Given this list of marker genes CDKN2A, BCL10, DKC1, PTPN22, COL17A1, TRANK1, BRAF, KRT6B, KRT17, CLCN6, HNF1A, NTRK1, PHOX2B, UCP2, BIRC3, EPAS1, THPO, KIF1A, GNA14, ATP1A2, RET, SLC12A3, CFTR, SDHD, WNT10A, BOLA3, YY1, FLRT1, CACNA1S, ZNF365, USB1, NOP10, SLURP1 (secreted LY6/PLAUR domain containing 1), HPGD, GABRA3 (gamma-aminobutyric acid type A receptor subunit alpha3), WNK1, NPM1, TERC, TINF2, ADAMTS15, SDHB, IKBKG, HEXB, SLC25A11 (solute carrier family 25 member 11), MPL, CTNNB1, TERT, PARN, RSPO1, GLA, HINT1 (NCBI Gene Id 3094), CCND1, KCNJ11, TNFSF4, ATP1A3, KCNA1, IGF2, MALT1, MOG, SCN11A, TAT, IGHMBP2 (immunoglobulin mu DNA binding protein 2), HLA-DRB1, DST, KIF1B, CACNA1A, NECTIN1, HMBS, CLCF1, PLAA, JUP, H19, SUCLG1, MAX, TP53, LPAR6, FBXO11, ZNRF3, SLC39A14, SHQ1, DNMT3A (DNA methyltransferase 3 alpha), HCRT, HLA-DQB1, FGFR2, P4HA2, KRT16, ALDOB, KRT5, FOXP1, LIFR, MBTPS2, FH, SERPINB7, CRLF1, KRT1, CTC1, SPR, CNBP, KCNJ18, KRT14, KRT9, MAP2K2, SDHAF2, VHL, FUCA1, KLC2, CDH3, HLA-B, SPRED2, CTSH, CUL4B, CLCNKB, AIP, TRPV3, MEN1, TYMS, HNRNPK, DLST, RETREG1, SLCO2A1, SDHA, COL6A1, TMEM127, NLRP3, GRB10, LAMB3, SLC18A2, CTSB, SLC1A3, CDH23, ABCC8, CDSN, SDHC, HNF4A, MDH2, NF1, MAP2K1, DDC, PRNP, DSG1, NHP2, NGLY1, PERP, ELP1, SUCLA2, AQP5, JAK2, KRT6A, SCN9A, P2RY11, GPR101, HRAS (HRas proto-oncogene, GTPase), RTEL1, WRAP53, PRKAR1A, here is a description of the gene set: studied in species Homo sapiens Abnormal excessive perspiration (sweating) despite the lack of appropriate stimuli like hot and humid weather. Human Gene Set: HP_HYPERHIDROSIS Hyperhidrosis